Given this list of marker genes RASA1, HRAS, SPHK1, PRKACA, VAV3, BCAR1, MAPK11, ITGB3, PAK1, SH2D2A, CTNNB1, ABI2, CYBA, DOCK1, RAC1, ACTG1, NRP2, ITPR2, THEM4, FLT1, ABI1, PGF, ITGAV, NCK2, SHB, PRR5, HSPB1 (NCBI Gene Id 3315), JUP, FLT4, MAPK13, PRKCZ, NCF2, AXL, NCF4, MAPKAP1, CTNNA1, NRP1, ROCK2, PRKACG, VAV2, MAPK12, HSP90AA1, VEGFC, NCKAP1, PAK3, PRKCB, CRK, PIK3R2, CYFIP1 (NCBI Gene Id 23191), CDH5, SHC2 (NCBI Gene Id 400665), WASF3, MAPK14, AKT3, MLST8, NCKAP1L, CALM1, ITPR1, SRC, NCK1, MAPKAPK3, ITPR3, BRK1, WASF1, AKT1, CYBB, PRKACB, CAV1, RICTOR, AKT2, ELMO2, PRKCD, VEGFA, PTK2, ELMO1, ROCK1, PAK2, BAIAP2, KRAS, PTK2B, CDC42, VAV1, FYN, PIK3CB, ACTB (actin beta), AAMP, TRIB3, PIK3CA, PLCG1, PIK3R1, CTNND1, NOS3, RHOA, NRAS, VEGFD, CYFIP2, MAPKAPK2, PXN, WASF2, PRKCA, PDPK1, VEGFB, KDR, NCF1, MTOR, AHCYL1, here is a description of the gene set: studied in species Homo sapiens Human Gene Set: REACTOME_SIGNALING_BY_VEGF Signaling by VEGF